Given this list of marker genes Polr3e, Polr3a, Polr3b, Polr3c, Crcp, Polr2e, Polr2h, Polr3d, Polr3h, Polr3g, Polr3k, Polr3gl, Polr3f, Polr1c, Polr1d, Polr2l, Polr2k, Polr2f, here is a description of the gene set: RNA polymerase III, one of three nuclear DNA-directed RNA polymerases found in all eukaryotes, is a multisubunit complex; typically it produces 5S rRNA, tRNAs and some of the small nuclear RNAs. Two large subunits comprise the most conserved portion including the catalytic site and share similarity with other eukaryotic and bacterial multisubunit RNA polymerases. The remainder of the complex is composed of smaller subunits (generally ten or more), some of which are also found in RNA polymerase I and others of which are also found in RNA polymerases I and II. Although the core is competent to mediate ribonucleic acid synthesis, it requires additional factors to select the appropriate template. Mouse Gene Set: GOCC_RNA_POLYMERASE_III_COMPLEX studied in species Mus musculus